Given this list of marker genes TADA3, ATR, EP300, TP53, E2F3, CDKN1A, CCND3, CDK4, CCND2, E2F2, CDK6, RB1, ATM, E2F1, CCND1, here is a description of the gene set: p300-p21-Cell cycle G1/S. Pathway ID: N00347. Pathway type: Reference. Pathway class: nt06166 Human papillomavirus (HPV). Pathway Definition from KEGG: (ATM,ATR) -> TADA3 -> EP300 -> TP53 => CDKN1A -| (CCND+CDK4/6) -> RB1 // E2F Human Gene Set: KEGG_MEDICUS_REFERENCE_P300_P21_CELL_CYCLE_G1_S studied in species Homo sapiens